The following is a description of a gene set: Human Gene Set: PID_RHOA_REG_PATHWAY Regulation of RhoA activity species: Homo sapiens from publication Schaefer CF, Anthony K, Krupa S, Buchoff J, Day M, Hannay T, Buetow KH (PMID 18832364), and this is the list of marker genes: ARAP3, DEF6, NGEF, PLEKHG6, ARHGDIA, ARHGAP5, MYO9B, ARHGEF12, ECT2, ARAP1, ARHGDIG, CDKN1B, ARHGEF2, ARHGAP9, ABR, VAV2, ARHGEF5, ARHGAP4, NET1, ARHGAP8, ARHGEF1, ARHGAP35, ARHGEF28, SRGAP1, MCF2, ARHGAP6, ARHGDIB, VAV3 (vav guanine nucleotide exchange factor 3), FARP1, ARHGEF3, ARHGEF10, MCF2L, ARHGEF15, DLC1, OBSCN, ARHGEF11, AKAP13, ARHGEF25, VAV1, OPHN1, ARHGEF17, ARHGEF18, TRIO, BCR, RHOA, ARHGEF10L